The following is a description of a gene set: Genes up-regulated in skin with IL1R1 knockout: uninfected versus S. aureus infection. Human Gene Set: GSE36826_NORMAL_VS_STAPH_AUREUS_INF_IL1R_KO_SKIN_UP Neutrophil abscess formation is critical in innate immunity against many pathogens. Here, the mechanism of neutrophil abscess formation was investigated using a mouse model of Staphylococcus aureus cutaneous infection. Gene expression analysis of S. aureus-infected skin revealed that induction of neutrophil recruitment genes was largely dependent upon IL-1beta/IL-1R activation. Unexpectedly, using IL 1beta reporter mice, neutrophils were identified as the primary source of IL-1beta at the site of infection. Furthermore, IL-1beta-producing neutrophils were necessary and sufficient for abscess formation and bacterial clearance. S. aureus-induced IL 1beta production by neutrophils required TLR2, NOD2, FPRs and the ASC/NLRP3 inflammasome. Taken together, IL-1beta and neutrophil abscess formation during an infection are functionally, spatially and temporally linked as a consequence of direct IL-1beta production by neutrophils. from publication Cho JS, Guo Y, Ramos RI, Hebroni F, Plaisier SB, Xuan C, Granick JL, Matsushima H, Takashima A, Iwakura Y, Cheung AL, Cheng G, Lee DJ, Simon SI, Miller LS (PMID 23209417) species: Homo sapiens, and this is the list of marker genes: NDUFA1, PCM1, ENOSF1, DUSP14, CACNA2D3, BLNK, IGFBP4, ADCK2, MANEA, ABL1, ATP6V1H, CNPY2, DTNB, SCPEP1, GAS6, WWP1, ATRAID, CD38, IQCG, UNG, GNS, PIK3R3, DSC2, FOXRED2, NEU1, PGAP3, FCGBP, HSD17B8, KANK2, ADRB2, ABCG1 (NCBI Gene Id 9619), GRAMD4, COMMD9, LINC00342, RBMS1, FERRY3, CDR2, ACAT1 (NCBI Gene Id 38), TMEM62, STAG3, PEPD, MGST2, CKAP5, LYSET, SLC17A5 (solute carrier family 17 member 5), LRPAP1, EXTL2, SLC2A5, TULP4, FAM222B, ECM1, DAG1, PINK1, TMC6, KDSR, TIMP2, VGLL4, LY96, RBP1, ANKRD46, CASP6, DUSP3, BLVRB, CTNNBIP1 (NCBI Gene Id 56998), HPF1, ACSL3, NR1H3, CRHBP, SIDT1, TRPV4, HRH1, PFKM, HHAT, SLC47A1, MTSS1, CD59, ITSN1, FZD5, SLC5A3, DYRK4, PSAP, RPS6KA2, SREBF1, ERP29, TMEM59 (transmembrane protein 59), PEBP1, MRPS33, RWDD1, PCBD1, CYBC1, DUSP7, QPRT, PIGK, LGR4, USP9Y, MCOLN1, SLC8B1 (NCBI Gene Id 80024), STARD13, DPY19L1, GCHFR (NCBI Gene Id 2644), MFHAS1, HEBP1, CMAHP (cytidine monophospho-N-acetylneuraminic acid hydroxylase, pseudogene), ZMYM3, F13A1, VAT1, CRTAP, ZNF589, SYPL1, UQCRQ, BPHL, RBM38, MTPAP, ARMC9, TNFSF12, OSBPL1A, EXT2, GAS7, NUPR1, TSPAN4, CDK4, CHKA, HS2ST1, NRP1, IGF2R, RETSAT, PPM1H, ZDHHC24, MAPRE2, NDFIP1, SLC29A1, SCCPDH, ASRGL1, TTC23, ASAH1, CST3, WDR7, PLD1, SRRD, ERCC2, B3GNT2, SLC2A9 (NCBI Gene Id 56606), OSBPL3 (NCBI Gene Id 26031), BTN3A3, TBC1D16, COQ7, ENTR1 (NCBI Gene Id 10807), SNX6, TCEA2, IPO13, SECTM1, PGGHG, CAPRIN2, FHIT, CCDC51 (coiled-coil domain containing 51), LPCAT3, RAD51AP1, SLC37A4, EPB41L2, UNC13B, FXYD6, CFD, NCF4, CTSF, BRF2, DHRS11, AAMDC, CD28, SIGIRR, NDRG3, SCAMP1, UBA7, TEX2, AKR7A3, SORD, DGLUCY, ACO1, RRAGD, UAP1L1, SIGLEC15, KCNMA1, SERPING1, MDH1, HADH, MYLIP, PLEKHA1, SLC38A6, PIP4K2B, STX3, NSL1, APPL2, TRIM32, FOLR2, RAP2B, PBXIP1, MSR1 (macrophage scavenger receptor 1), IQCK, MBD4 (NCBI Gene Id 8930), ACP2